Given this list of marker genes OAS1, RTP4, OAS3 (2'-5'-oligoadenylate synthetase 3), IFI27, IFITM3P7, IRF3, IRF1, SP110, STAT1, IFNB1, OASL, IFITM1, ISG20, IRF9, OAS2 (2'-5'-oligoadenylate synthetase 2), IFI44, MX1, IFI30, IFRD1, IFI16, ISG15, IFITM3, IFIT2, MX2, here is a description of the gene set: Human Gene Set: ZHANG_INTERFERON_RESPONSE Respiratory syncytial virus (RSV) infection is one of the major causes of respiratory tract infection for which no vaccine or antiviral treatment is available. The RSV NS1 protein seems to antagonize the host interferon (IFN) response; however, its mechanism is unknown. Here, we used a plasmid-borne small interfering RNA targeting the NS1 gene (siNS1) to examine the role of NS1 in modulating RSV infection. RSV replication was reduced in A549 cells, but not IFN-deficient Vero cells, transfected with siNS1. siNS1 induced upregulated expression of IFN-beta and IFN-inducible genes in A549 cells. siNS1-transfected human dendritic cells, upon RSV infection, produced elevated type-1 IFN and induced differentiation of naive CD4+ T cells to T helper type 1 (TH1) cells. Mice treated intranasally with siNS1 nanoparticles before or after infection with RSV showed substantially decreased virus titers in the lung and decreased inflammation and airway reactivity compared to controls. Thus, siNS1 nanoparticles may provide an effective inhibition of RSV infection in humans. species: Homo sapiens from publication Zhang W, Yang H, Kong X, Mohapatra S, San Juan-Vergara H, Hellermann G, Behera S, Singam R, Lockey RF, Mohapatra SS (PMID 15619625) Interferon-inducible genes up-regulated in A549 cells (lung cancer) infected with a respiratory syncytial virus (RSV) that had its NS1 gene knocked down by RNAi.